The following is a description of a gene set: species: Homo sapiens Human Gene Set: GOMF_ASPARTIC_TYPE_ENDOPEPTIDASE_INHIBITOR_ACTIVITY Binds to and stops, prevents or reduces the activity of aspartic-type endopeptidases., and this is the list of marker genes: NLRP7, BIN1, WFDC2, PRNP, SORL1, GAPDH, CRB2